Given this list of marker genes PHB2, CHCHD10, MICU2, TIMM23, TIMM10B, DNAJC15, PDSS1, APOO, PDSS2, MTX1, MICU3, MICU1, SAMM50, SLC25A6, MTX3, TIMM23B, DNAJC11, APOOL, AGK, SMDT1, MPC1, GRPEL1, MCU, CHCHD6, MICOS13, MTX2, MCUB, TIMM9, AFG3L2, TIMM17A, TIMM10, ROMO1, TIMM22, IMMP2L, CHCHD3, MPC2, TIMM50, PAM16, PHB1, IMMT, DNAJC19, HSPA9, TIMM44, TIMM29, MICOS10, TRMT10B, TIMM21, SPG7, IMMP1L, TIMM17B, GRPEL2, here is a description of the gene set: species: Homo sapiens Human Gene Set: GOCC_INNER_MITOCHONDRIAL_MEMBRANE_PROTEIN_COMPLEX Any protein complex that is part of the inner mitochondrial membrane.